The following is a description of a gene set: Mouse Gene Set: chr12A1 species: Mus musculus, and this is the list of marker genes: Gdf7, Gm9158, Gm35638, Gm22845 (NCBI Gene Id 115488038), Gm46339, Msgn1, Hs1bp3, Taf1b, Gm49760, Gm22766, Rrm2, Lpin1, Gm36723, 4930448C13Rik, Gm5954, Atad2b, Kcns3, Gm18774, Gm36236, Gm3678, Ttc32, Gm36287, Gm36752, Gm4294, Zfp996, Gm18696, Gm23979, Tubb2a-ps2, Pdia6, Gm47446, 2810032G03Rik, Gm49327, Gm46312, Laptm4a, Ywhaq, Gm46342, Gm9286, Gm9292, Kidins220, Gm48201, Gm46323, Gm26520, Gm48310, Gm31332, Gm5182, Gm22748, Gm23676, Gm5652, Gm32828, Gm35725, Cyria, Nt5c1b, 1700022H16Rik, Greb1, Gm9265 (predicted gene 9265), Gm48606, Gm9139, Klf11, Gm9071, Gm33037, Gm19340, Gm20472, Gm26211, Gm35208, Ddx1, Gm49248, Adam17, Gm7099 (predicted gene 7099), Pfn4, Gm9318, Gm5432, Nfyc-ps, Gm9309, Gm23167, Gm48355, Wdr35, Gm48608, Gm19084 (NCBI Gene Id 100418227), Gm9237, Gm35890, Iah1, Pgk1-rs7, Apob, Gm9305, Nol10, Gm49328, Gm16372 (NCBI Gene Id 636168), Slc66a3, Rab10, Gm6867, 5730507C01Rik, Mrto4-ps1, Rpl21-ps2, Gm46313, 3110053B16Rik, Gm9259, Gm46338, Gm38407, 7420701I03Rik, B430203G13Rik, Gm9077, Gm4804, Vsnl1, Gm20348, Gm4425 (NCBI Gene Id 432637), Gm19368, Gm19196, Wdcp, Gm4419, Dnmt3aos, Gm9231, Gm46311, Gm40881, Gm10330, Gm7126, Gm22303, Gm9257, Id2, 2900045O20Rik, Cpsf3, 9530020I12Rik, Gm18114, Gm40271, Gm29696, Cys1, Osr1 (NCBI Gene Id 23967), Gm31938, Itsn2, Gm25610, Gm17330, Slc7a15, Ubxn2a, Lratd1, Sdc1, Gm5953, Rdh14, Fam228b, Gm24208, Gm18387, Gm16497, Gm21941, Gm6969, Asap2, Gm40849, Gm40879, Gm35298, Gm9321, 4921511I17Rik, Gm17915, Mir7675, Bnip3l-ps, Gm36495, Gm36372, Hpcal1, Mycn, Gm26449, Gm48012, Gm40853, Gm18244, Gm45925, 2410018L13Rik, Gm20486, Rhob, Ldah, Gm4755, Gm17816, Gm3625, Gm17541, Rpl36-ps3, Atp6v1c2, Gm10479, Gm9847, Gm9075, 3732407C23Rik, Gm34637, Gm46336, Gm9255, Gm9072, Dnajc27, Dnmt3a, Nbas, Gm9315, 2410004P03Rik, Gm9088, Klhl29, Mir6387, Gm9249, Gm19786, Adcy3, Efr3b, Gm4036, Gm23298, Gm4012, Smc6, Gm5977, Trib2, Gm7093, Gm17746, Odc1, Gm32442, Gm30124, Gm9293, Gm9202, Fkbp1b, Zfp125, Gm16476, Pomc, BC106175, E2f6, Ncoa1, Gm21297, Gm4120, Kcnf1, Gm36235, Sf3b6, Gm10054, Gm25821, Grhl1, Gm4803, Gm9194, Dtnb, Gm48071, Rps7-ps2, Gm9289, Gm18337, 2900060N12Rik, 4921501I09Rik, Cenpo, Itgb1bp1, Gm6736, Gm38699, 4930511A02Rik (NCBI Gene Id 74712), Rock2, Pum2, Matn3, Gm3838 (NCBI Gene Id 100042426), Mfsd2b, Gm20474, Gm6682, Gm6838, 1700030C10Rik, Rad51ap2, Gm4927, Gm9285, Gm9269, Gm4929, Asxl2, Rab10os, 1110002L01Rik, Ptrhd1, Kif3c, Mrto4-ps2, Gm20336, 1700101O22Rik, 1700034J04Rik, Mboat2, Gen1, 9030624G23Rik, 5033421B08Rik, Gm4928 (predicted gene 4928), Gm36862, Gm9110, Gm34237, Gm5784, Gm40847, Ntsr2, 4930519A11Rik, 9930038B18Rik, Fam228a (family with sequence similarity 228, member A), Mir3066